The following is a description of a gene set: Mouse Gene Set: GOBP_POSITIVE_REGULATION_OF_FILOPODIUM_ASSEMBLY species: Mus musculus Any process that activates or increases the frequency, rate or extent of the assembly of a filopodium, a thin, stiff protrusion extended by the leading edge of a motile cell such as a crawling fibroblast or amoeba, or an axonal growth cone., and this is the list of marker genes: Pik3r1 (NCBI Gene Id 328326), Ccl21d, Plppr5, Actr3, Fmr1, Palm, Dpysl3, Tenm2, Tgfbr1, Cdc42, Fscn1, Srf, Tenm1, Prkcq, Neurl1a, Mien1, Agrn, Ripor2, Arpc2, Myo3a, Rhoq, Fnbp1l, Ccl21e, Myo3b, Wasl, Zmynd8, Tgfb3, Gpm6a, Ccl21a, Rac1, Dnm3, Ccl21b, Nlgn1, Ccl21f, Dock11, Nrp1, Rala, Arap1, Espn, Ccr7